The following is a description of a gene set: A specialized area of membrane on either the presynaptic or the postsynaptic side of a synapse, the junction between a nerve fiber of one neuron and another neuron or muscle fiber or glial cell. studied in species Mus musculus Mouse Gene Set: GOCC_SYNAPTIC_MEMBRANE, and this is the list of marker genes: Cntn6, Chrna10, Zdhhc17 (zinc finger, DHHC domain containing 17), Slc6a5, Grin2b, Shisa7, Stx4a, Slitrk2, Grm7, Kcnma1, Cplx3, Scn10a, Kcnn2, Dcc, Shank2, Syde1, Cacng3, Grm4, Lrp4, Gabbr2, Ndufs7 (NADH:ubiquinone oxidoreductase core subunit S7), Olfm2, Bcan, Bsn (bassoon), Syap1, Rnf10 (ring finger protein 10), Asic2, Grik3, Chrm4, Nbea, Scn1a, Slc2a3, Fbxo45, Dgki, Ptprf, Lrrc4c, Tiam1, Akap9, Gria3, Psenen, Susd4, Akap5, Grin2c, Srgap2, Sema4b, Ptprs, Rgs9 (NCBI Gene Id 19739), Itgb4, Igsf9b, Snph, Tenm3, Arrb2, Scn8a, Marcks, C1qb, Usp48, Drd1 (NCBI Gene Id 77537, dopamine receptor D1), Ctbp1, Asic1, Gria4, Nptn, Palm, Stx11, Cltc, Slc1a6, Htr2a, Mpp2, Clstn3, Igsf9, Kcna3, Chrna4, Kcnk2, Slc22a2, Neto2, Adam22, Dlg2, Snap91, Kctd12b, Grin3a, Shank3, Sez6l, Abhd17b, Chrng, Gabrg1, Ntrk2, Gabra2, Slc4a8, Kctd16, Lrfn5, Glra1, Nlgn3, Htt, Rims1, Eno1 (NCBI Gene Id 269605), Adra2a, Chrnb3, Lrrtm3, Chrnb2 (cholinergic receptor nicotinic beta 2 subunit), Dbn1, Pacsin1, Dlg4, Chrm1, Prrt1, Atad1, Cacng7, Pdlim4, Mkln1, Sorcs2, Col13a1, Drd5, Slc1a7, Glra3 (glycine receptor, alpha 3 subunit), Prkcg, Napepld, Clta, Itpr1, Clcn3, Kcna4, Cdh9, Slc8a3, Lpar1, Cacng2, Cfl1, Slc6a7, Cdh8, Kcnd3, Shisa6, Unc13b, Atp2b1, Cacna2d2, Trappc4, Chrna9, Hspb1, Atp1a3, Ncam2 (neural cell adhesion molecule 2), Znrf2, Itga5, Slitrk1, Rims4, Shc4, Kcnt1, Ap2m1, Tenm2, Gphn, Ntng2, Phb1, Oprk1, Kcnc3, Il31ra, Chrnb4, Kcna2, Lin7b, Nectin1, Grm2, Gpr156, Cnih2 (NCBI Gene Id 12794), Unc13a, Lingo2, Cyth1, Eno1b, Slitrk3, Cacng4, Gnao1, Fxyd6, Slc6a4, Kctd12, Glra4, Ank3 (NCBI Gene Id 73013), Fbxo2, P2rx1, Ano6, Flrt3, Kcnj9, Pcdh10, Nt5e, Magi2, Gpr151, Nsg1, Ank1, Gabrb2, Hspa8, Lzts1, Kcnj6, Sema4f, Slc30a1, Efnb3, Nsg2, Dlgap1, Stx2 (syntaxin 2), P2rx3, Grip1, Entpd1, Adora1, Slc8a1, Chrnd, Adgrl3, Clmp, Cnr1, Synj1, Gria1, Dnajc6, Casr, Mpp4, Rgs7, Neo1, Gpc4, Gabrg3, Lrrc4b, Magee1, Stxbp5, Glrb, Syt1, Itga3, Hip1, Crkl, Chrna5, Lrrc7, Comt, Dnm1, Septin7, Apba1, Ptpn5, Cntn5, P2rx2, Gnb5 (NCBI Gene Id 14697), Dagla, Abhd17c, Slc12a5, Syt3, Clstn1 (calsyntenin 1), Strn (NCBI Gene Id 268980), Gabrb3, Kcnd2, Cltb, Ache, Lrrtm2, Cadm3, Atp2b3, Vdac1, Ntng1, Kcnc1, Gabrb1, Cpe, Epha4, Htr7, Sorcs3, Grin2a, Unc13c, Erbb4, Syne1, Gpr158, Syde2, Adora3, Kcnj8, Akap1, Cnksr2, Psen2, Lrrtm1 (NCBI Gene Id 74342), Slc5a7, Kcnc4, Arc, Marcksl1, Gabra5, Napb, Grid2ip, Srpx2, Adam11, Aph1a, Kcnj3, Tmem240, Flrt2 (fibronectin leucine rich transmembrane protein 2), Met, Adra2c, Plxnb1, Gabrd, Fmr1 (NCBI Gene Id 207836), P2ry4, P2rx6, Flot2, Cacng8, Il1rapl1 (NCBI Gene Id 76162), L1cam, Gabrg2, Vangl2, Atg9a, Slc16a3, Ctnnb1, Cdh10, Gabra4, Kcnj4, Apbb1, Nrp1, Dtnbp1, Elfn2, Anxa1, Afdn, Acp4, Scrib, Ano2, Psen1, Drd4, Igsf21, Gabrr2, Gsg1l, Cask, Shisa9, Gpr179 (NCBI Gene Id 544812), Drd3, Pde2a, Cacng5, Slc6a6, Shank1, Ptch1, Pcdh8, Otof, Atp2b2, Dennd1a, Tmub1, Nipsnap1, Tacr1, Eno2, Chrm2, Ap2b1, Csmd2, Utrn (utrophin, NCBI Gene Id 22288), Kcnab2, Grm8, Rapsn, Ano1, Cacna1e, Htr1b, Nrp2, Rala, Cntnap2, Kif1b, Slc6a1, Ryk, Celsr3, Nlgn1, Lrfn4, Septin3, Gad2 (glutamic acid decarboxylase 2), Efnb2, Chrna3, Erbb2, Oprl1, Slc6a9, Hcn1, Gper1, Kcnq5, Nlgn4l, Ngfr, Chrnb1, Dlg1, Syt11, Sema4c (NCBI Gene Id 98332), Cadm4, Scn11a, Glra2, Itgb1, Lrp1, P2ry1, Snta1, Neto1, Grik4 (NCBI Gene Id 244825), Gabre (gamma-aminobutyric acid (GABA) A receptor, subunit epsilon), Ptprt, Grik2, Cadm1, Grin2d (glutamate receptor, ionotropic, NMDA2D (epsilon 4)), P2ry2, Iqsec3, Ap2s1, Nrxn2, Ntrk3, Ppp1r9b, Oprd1, Dmd, Efnb1, Lrfn2, Igsf11, Chrna2, Cyth2 (cytohesin 2), Htr3b, Adcy8, Ptpra, Egfr (NCBI Gene Id 13649), Kcnd1, Lhfpl4, Crhr1, Slc1a2, Faim2, Gabrr1, Lrrtm4, Stx1b, Slc6a2, Lpar2, Rab3gap2, Dnm1l, Notch1, Atp6ap2, Adam10, Lin7a, Cacna1c, Pnoc (NCBI Gene Id 18155), Prr7, Lrrc4, Rap2a, Lrfn1, Cacna1a, Adgrb1 (NCBI Gene Id 97994), Syt7, C1qa, Pten, Dgkb, Kcnj11, Adrb2, Grip2, Exoc3, Lin7c, Grin1, Gabrr3, Cacna1d, Itgb5 (NCBI Gene Id 16419), Syt6, Cadps2, Pick1, Actn2, Cspg5, Adra1a, Zc4h2, Nrgn, Vwc2, Gabra1, Syp, Adgrl1, Picalm, Chrna1, Ephb2, Rab5a, Dnaja3, Shisa8, Pi4k2a, Slc6a11, Kcnj2, Ptpro, Dnm3, Arrb1, Nrg1, Ddn, Tamalin, Grik1, Slitrk5, Plppr4, Ninj1 (ninjurin 1), Lrp8, Nectin3 (nectin cell adhesion molecule 3), Syndig1 (NCBI Gene Id 99331), Adcy1, Farp1, Cryab (crystallin, alpha B), Gria2, Nrxn3, Robo2, Cntn2, Erc2, Gabrq (NCBI Gene Id 57249), Ptprd, Slc6a8 (solute carrier family 6 (neurotransmitter transporter, creatine), member 8), Snap25, Fosl1, Rph3a, Lrfn3, Dlg3, Anp32e, Slc16a7 (NCBI Gene Id 71535), Napa (NCBI Gene Id 67002), Chrna6, Gabbr1, Epn1 (epsin 1), Slc8a2, Epha7, Stx19, C1qc, Grm3, Erbb3, Kctd8, Itsn1, Fzd3, Grid2, Slc6a3, Musk, Grin3b, Cbln1, Itgb3, Adgrl2, Chrne, Drd2, Cdh2 (NCBI Gene Id 12558), Cnih3, Clstn2, Slc9a5, Adam23, Ctnna2, Pip5k1c, Ptprz1, Hip1r, Atp2b4, Scn2a, Grik5, Cntnap4, Olfm1, Sarm1, Tmem108, Grm6, Fgf22, Elfn1, Podxl, Kcnc2, Gripap1, Chrm3, Nptx2, Kcna1, Sigmar1, Rgs7bp, Gabra6, Dok7, Baiap2, Clcn2, Sema4d, Trpv1, F2r (coagulation factor II thrombin receptor), Htr5a, Abhd17a, Ank2, Src, Chrna7, Itga8, Rims3, Gabra3, Ppfia2, Cntn1, Dbnl, Stx1a, Kcnk1, Stxbp1, Canx, Grid1, Ncam1, Ghsr, Nrxn1, Nlgn2, Rtn4 (reticulon 4), Kcnb1, Cacna2d1, Cxadr (coxsackie virus and adenovirus receptor, NCBI Gene Id 70446), Dnm2, Mtmr2, Ncstn, Grm1 (NCBI Gene Id 74875), Rac1, Dag1, Fcho2, Abhd6, Prrt2, Oprm1, Adora2a, Pcdh17, Cacna2d3, Npy1r, Rims2, Nrcam, Sspn, Itsn2, Adgrb3, Grm5, Htr3a, Gpm6a, Cacna1h, Epb41l1, Iqsec2, Kcnh1, Htr1a, Pcdhb16, Chrm5